Given this list of marker genes WASF1, FCHSD2, WASF2, WHAMM, ABI2, TRIM27, SCIN, WASF3, BRK1, NCKAP1, GSN, CYFIP1, MAGEL2, here is a description of the gene set: Human Gene Set: GOBP_POSITIVE_REGULATION_OF_ACTIN_NUCLEATION species: Homo sapiens Any process that activates or increases the frequency, rate or extent of actin nucleation, the initial step in the formation of an actin filament in which actin monomers combine to form a new filament.